The following is a description of a gene set: studied in species Mus musculus Binding to a 7SK small nuclear RNA (7SK snRNA). Mouse Gene Set: GOMF_7SK_SNRNA_BINDING, and this is the list of marker genes: Larp7, Ddx21, Celf3, Larp7-ps, Ccnt1, Mepce, Ccnt2 (NCBI Gene Id 97606), Cdk9, Hexim2, Hexim1